Given this list of marker genes Kdm3b, Jmjd1c, Kdm3a, Kdm4d, Kdm7a, Kdm4b, Kdm4c, Kdm4a, Hr, Kdm1a, Phf8, Phf2, here is a description of the gene set: Mouse Gene Set: GOMF_HISTONE_H3K9_DEMETHYLASE_ACTIVITY Catalysis of the removal of a methyl group from a modified lysine residue at position 9 of the histone H3 protein. studied in species Mus musculus